Given this list of marker genes Trf, B2m, Hjv, Tfrc, Tfr2, Hfe, here is a description of the gene set: Mouse Gene Set: GOCC_HFE_TRANSFERRIN_RECEPTOR_COMPLEX species: Mus musculus A protein complex containing at least HFE and a transferrin receptor (either TFR1/TFRC or TFR2), proposed to play a role in the sensing of transferrin-bound Fe (Fe2-Tf) on the plasma membrane to regulate hepcidin transcription.